The following is a description of a gene set: Aplasia/Hypoplasia of the ribs studied in species Homo sapiens Human Gene Set: HP_APLASIA_HYPOPLASIA_OF_THE_RIBS, and this is the list of marker genes: GPC3, ATP6V1B2, NEK1, HDAC6, ALDH1A2, IFT172, DYNC2H1, BMP2, NALCN, DDR2, KMT2A, RUNX2, ALG12, INPPL1, FLI1, INTU, HSPG2, ALPL, SLC35D1, SF3B4 (NCBI Gene Id 171), SRCAP, GPC4, SETBP1, HES7, FGFR3, LBR, MYF5, TBX6, FUZ, MMP23B, IFT122, NFASC, COL11A1, NUP88, GPX4, RPS19, SKI, EVC, SOX9, ROR2, IFT43, TBX4, WNT3, PRKCZ, PAICS, SCUBE3, ERMARD, SLC26A2, KCNAB2, COL2A1, PLCB3 (NCBI Gene Id 5331), IHH, IFT140, CEP152, WDR35, RTL1, TOR1A, VAC14, B4GAT1, NKX3-2, B3GALT6, TBX5, CUL7, PRDM16, WNK3, IFT80, SOX2, FBN1, RNU4ATAC, TAPT1, SNRPB, CASZ1, GNPTAB, SCARF2, BMPER, EVC2, FLNA, RRAS2 (NCBI Gene Id 22800), DPYSL5 (dihydropyrimidinase like 5), MEG3, DHCR24, FLNB, CCDC22, DYNLT2B, PRIM1, UBA1, HNRNPR, DYNC2I1, RERE (arginine-glutamic acid dipeptide repeats), CPLANE1, PDPN, DLK1, PTH1R, ATR, VPS35L, RSPO2, CEP120, ORC6, PORCN, PUF60, IFT81, C2CD3, NSDHL, SMO, TRPV4, WASHC5, DDRGK1, TRPV6, TBC1D24, LAMA5, KYNU, FIG4, GABRD, PTCH1, CSPP1, SPEN, PAM16, RNU12, TRIP11, TBCK, COL11A2, UBE4B, DYNC2I2, LUZP1, B3GAT3, CENPJ, SIX6, VANGL1, ORC1, DNMT3A, DONSON, LMX1B, DYNC2LI1, EZH2, PTPN11, KIAA0586, CHD6, CHST3